The following is a description of a gene set: Mouse Gene Set: GOBP_DRINKING_BEHAVIOR species: Mus musculus The specific behavior of an organism relating to the intake of liquids, especially water., and this is the list of marker genes: Ace2, Cyp11b2, Pmch, En1, Ucn (NCBI Gene Id 22226), Agtr1a, Hrh3, Mmp17, Agt, Apln, Slc24a4, Agtr1b, Htr1b, Ren1, Drd2, Tacr1, Oxt